The following is a description of a gene set: White fat cell differentiation Human Gene Set: WP_WHITE_FAT_CELL_DIFFERENTIATION studied in species Homo sapiens, and this is the list of marker genes: INS, NR2F2, NR1H3, DDIT3, WNT10B (NCBI Gene Id 82499), IRF4, KLF15, TLE3, TCF7L1, CEBPB, IRF3, STAT5A, KLF2, PPARG, CREB1, STAT5B, CEBPD, KLF4, SREBF1, ZNF423 (NCBI Gene Id 23090), RORA, EGR2, RARA, KLF5, MECOM, GATA3, CTNNA1, GATA2, CEBPA, FOXO1, NR3C1, EBF1